Given this list of marker genes NTRK3, IRS1, NTF3, PIK3R1, PIK3CA, SRC, here is a description of the gene set: Activated NTRK3 signals through PI3K Human Gene Set: REACTOME_ACTIVATED_NTRK3_SIGNALS_THROUGH_PI3K studied in species Homo sapiens